The following is a description of a gene set: Mouse Gene Set: GOBP_OLIGOSACCHARIDE_CATABOLIC_PROCESS The chemical reactions and pathways resulting in the breakdown of oligosaccharides, molecules with between two and (about) 20 monosaccharide residues connected by glycosidic linkages. species: Mus musculus, and this is the list of marker genes: Man2b1, Lct, Ctbs, Neu2, Hexb, Treh, Mgam, Neu3, Gm2a, Neu4 (sialidase 4), Manba, Sis, Neu1, Man2b2, Man2c1